The following is a description of a gene set: Mouse Gene Set: GOBP_NEGATIVE_REGULATION_OF_MONOCYTE_CHEMOTAXIS studied in species Mus musculus Any process that decreases the frequency, rate, or extent of monocyte chemotaxis., and this is the list of marker genes: Nbl1, Ccn3, Slit2, Slamf8, Dusp1 (NCBI Gene Id 98098), Grem1